The following is a description of a gene set: species: Homo sapiens part of: Selective autophagy Triglycerides stored in lipid droplets are hydrolysed under nutrient starvation to release fatty acids for energy. The content of lipid droplets may vary but they are all coated with a protective protein called perilipin. When this protein is degraded, lipid droplets associate with autophagic components and breakdown into fatty acids (Ward C et al. 2016, Schulze R J et al. 2017). This process is termed as lipophagy (Singh R et al. 2009). Reactome Pathway: Lipophagy, and this is the list of marker genes: PRKAB2, PRKAG3, PLIN3, PLIN2, PRKAA2, PRKAG2, PRKAB1, PRKAG1, HSPA8